The following is a description of a gene set: Mouse genes annotated to increased small intestine adenocarcinoma incidence (MP:0009309) retrieved from the Mouse Genome Informatics database via MouseMine from publication Motenko H, Neuhauser SB, O'Keefe M, Richardson JE (PMID 26092688) Mouse Gene Set: MP_INCREASED_SMALL_INTESTINE_ADENOCARCINOMA_INCIDENCE species: Mus musculus, and this is the list of marker genes: Apc, Smurf2, Pole, Lin28b, Mlh1, Msh2